The following is a description of a gene set: from publication Liu F, Lei W, O'Rourke JP, Ness SA (PMID 16205643) Human Gene Set: LIU_TARGETS_OF_VMYB_VS_CMYB_DN studied in species Homo sapiens Gene regulated in the opposite directions by v-MYB (DN) and c-MYB (UP) variants of CMYB overexpressed in primary monocyte cultures off adenoviral vectors. The v-Myb oncoprotein encoded by Avian Myeloblastosis Virus is highly oncogenic, induces leukemias in chickens and mice and transforms immature hematopoietic cells in vitro. The v-Myb protein is a mutated and truncated version of c-Myb, a DNA-binding transcription factor expressed in many cell types that is essential for normal hematopoiesis. Previous studies suggested that two types of differences, DNA binding domain mutations and the deletion of a C-terminal negative regulatory domain were important for increasing the transforming activity of v-Myb. Here, we combined structure-function studies of the v-Myb and c-Myb proteins with unbiased microarray-based transcription assays to compare the transcriptional specificities of the two proteins. In human cells, the v-Myb and c-Myb proteins displayed strikingly different activities and regulated overlapping, but largely distinct sets of target genes. Each type of mutation that distinguished v-Myb from c-Myb, including the N- and C-terminal deletions, DNA binding domain changes and mutations in the transcriptional activation domain, affected different sets of target genes and contributed to the different activities of c-Myb and v-Myb. The results suggest that v-Myb is not just a de-repressed version of c-Myb. Instead, it is a distinct transcriptional regulator with a unique set of activities., and this is the list of marker genes: FAM117A, GATA3, TM4SF1, CMAHP, IL6, NPIPA1, USP31, IL12B, PTPRJ, ADRB2, ENSG00000304732, CLEC5A, NKG7, TFPI2, YBX3, EHD1, ARHGAP24, DALRD3, CERS6, DENND10P1, EAF2, TSC22D3, PXK, CSGALNACT1, KLF5 (NCBI Gene Id 688), KCNA3, S1PR3, PALLD, FAM107B, COL4A2, GPR18, SLC38A1, CCL20, LINC01215, CCNA1, GNG2, TPSAB1, MAPKAPK2, CHSY1, NRIP3, CSF2, CDC42SE2, IL23A, OXTR, VCAN